Given this list of marker genes SLC29A1, SLC25A26, SLC28A2, SLC29A3, SLC29A2, SLC28A3, SLC29A4, SLC28A1, SLC22A1, SLC22A2, here is a description of the gene set: species: Homo sapiens Human Gene Set: GOMF_NUCLEOSIDE_TRANSMEMBRANE_TRANSPORTER_ACTIVITY Enables the transfer of a nucleoside, a nucleobase linked to either beta-D-ribofuranose (ribonucleoside) or 2-deoxy-beta-D-ribofuranose, (a deoxyribonucleotide) from one side of a membrane to the other.